Given this list of marker genes ZIC3 (Zic family member 3), HCN4, BVES, BMP10, BMP4, TBX5, TREX1, NOG, WNT2, EDNRA, PROX1, PITX2, TBX18, ENG, MESP1, GATA6, CACNA1G, MYH6, NKX2-5, ISL1, TBX3, GJB6, SHOX2, here is a description of the gene set: The process whose specific outcome is the progression of cardiac muscle of the atrium over time, from its formation to the mature structure. Human Gene Set: GOBP_ATRIAL_CARDIAC_MUSCLE_TISSUE_DEVELOPMENT studied in species Homo sapiens